The following is a description of a gene set: Mouse Gene Set: GOMF_TAT_PROTEIN_BINDING studied in species Mus musculus Binding to Tat, a viral transactivating regulatory protein from the human immunodeficiency virus, or the equivalent protein from another virus., and this is the list of marker genes: Dll1 (delta like canonical Notch ligand 1), Ctdp1, Actb, Smarca4, Gabarapl1, Mdfic, Npm1, Dnaja1, Smarcb1